Given this list of marker genes PKMYT1, PPME1, XPO1, TICRR, PLK1, WEE1, CDC25A, CCNB1, HJURP, CDC25B, PPP2R1B, PPP2R3B, PPP2CA, FOXM1, MIS18BP1, BORA, PPP2CB, FZR1, PPP2R2A, CDC25C, SGO1, CDK2, LCMT1, CDK1, CCNA1 (NCBI Gene Id 8900), MNAT1, PPP2R1A, OBI1, CCNA2, CCNH, CCNB2, CDK7, here is a description of the gene set: Cyclin A/B1/B2 associated events during G2/M transition Human Gene Set: REACTOME_CYCLIN_A_B1_B2_ASSOCIATED_EVENTS_DURING_G2_M_TRANSITION species: Homo sapiens